Given this list of marker genes CTSB, F11R, LRRC15, ITGAV, CDK1, EFNB3, CHMP4A, SLC52A1, CHMP3 (NCBI Gene Id 51652), TMPRSS4 (transmembrane serine protease 4), FUCA2, SCARB2, RPSA, XPR1, NUP153, PGLYRP2, CXCL8, NPC1, CHMP1B, LGALS9, VPS4B, ARL8B, CBL, CDHR3, CHMP4B, CD55, SLC20A2, SLC1A5, CLDN1, SLC3A2 (solute carrier family 3 member 2), TRIM21 (NCBI Gene Id 6737), LAMP3, CD4, TRIM25, ANPEP, ZNF639, GRK2, SELPLG, CLEC4M, LAMP1, MIR141 (NCBI Gene Id 406933), NECTIN2, WWP2, TNFRSF4, NECTIN1 (NCBI Gene Id 84853), CXADR, PPIA, RAB7A, SMPD1, PIKFYVE, HLA-DRB1, HSPD1, ITGB6, PGLYRP3, CR1, CLDN9, HYAL2, SLC10A1, CHMP7, DAG1, CHMP2B, EXOC7, CHMP5, HMGB1, SIVA1, GYPA, TRIM31, CHMP4BP1, ITCH, TRIM5, DDB1, PPARA, TRIM11, HSP90AB1, CLDN6, CAV2, NRP1, TPCN1, ITGA5, P4HB, ZNF502, WWP1, LTF, VPS37B, DYNLT1, CD74, PVR, EXOC2, ACE2, KRT6A, LDLR, HSPA1B, RNASEK, CHMP1A, CD81, TMPRSS2 (NCBI Gene Id 7113), VAMP8, SCARB1, FBLN1, CHMP6 (charged multivesicular body protein 6), NECTIN4, PGLYRP1, EGFR (epidermal growth factor receptor), TFRC, ILF3, AGTR1, TSG101, CD86, VAPA, CR2, ITGB1, SLAMF1, HSPA1A, CXCR4, JPT2, KPNA3, EPS15, TYRO3, GPR15, ITGB5, MIR130A, HTR2A, VPS18, TNFRSF14, AXL, CCR5, NECTIN3, HS3ST5, LGALS1, ITGB7, IFIT1, CH25H, SLC7A1, BSG, CHMP4C, SERPINB3, UVRAG, MYH10 (myosin heavy chain 10), CLEC5A, CD209, MYH9, MRC1, NCAM1, INSR, ITGA2, FURIN, PPID, SLC52A2, BPIFA1, TRIM62, SRC, VAPB, KIAA0319L, AVPR1B, INHBB, GAS6, EPHA2, CLEC4G, TRIM38, CTSL, ITGB3, MIR30C1, TPCN2, ICAM1, IDE, VPS4A, CD80, CD46, EFNB2, CHMP2A, SIGLEC1, DPP4, AVP, CAV1, PLSCR1, PC, MOG, HAVCR1, PHB1, here is a description of the gene set: An interaction between two organisms living together in more or less intimate association. The term host is used for the larger (macro) of the two members of a symbiosis; the various forms of symbiosis include parasitism, commensalism and mutualism. species: Homo sapiens Human Gene Set: GOBP_BIOLOGICAL_PROCESS_INVOLVED_IN_INTERACTION_WITH_HOST